The following is a description of a gene set: Mouse Gene Set: GOBP_IODIDE_TRANSPORT The directed movement of iodide into, out of or within a cell, or between cells, by means of some agent such as a transporter or pore. species: Mus musculus, and this is the list of marker genes: Slc5a6, Mfsd8, Tg, Slc26a7, Kcne2, Slc5a5 (solute carrier family 5 (sodium iodide symporter), member 5), Kcnq1, Slc5a8, Mtor, Ano1, Slc26a4 (solute carrier family 26, member 4)